Given this list of marker genes Guca1b, Guca2a, Ncs1, Guca1a, Guca2b, here is a description of the gene set: studied in species Mus musculus Binds to and increases the activity of guanylate cyclase. Mouse Gene Set: GOMF_GUANYLATE_CYCLASE_ACTIVATOR_ACTIVITY